Given this list of marker genes Car7, Drd2, Oxtr, Prkce, Cln3, Npy5r, Tac1, Pten, Cckbr, Slc38a1, Cntnap2, Hap1, Car2, Nalcn, Drd4, Plcl2, Kif5b, Adra1a, Kras (NCBI Gene Id 232521), Stxbp1, Nlgn2, Npas4 (neuronal PAS domain protein 4), Adora2a, Zdhhc3, Kcnk2, Zdhhc12, Nf1, Nlgn1, Phf24, Bdnf, Nisch (NCBI Gene Id 76966), Adora1, Cnr1, Baiap3, Nrxn1, Htr1b, Usp46, Tacr1, Cnr2, Slc6a1, Cntnap4, Dbi, Erbb4, Plcl1, Nps, Grik1 (NCBI Gene Id 28183), here is a description of the gene set: Any process that modulates the frequency, rate or extent of GABAergic synaptic transmission, the process of communication from a neuron to another neuron across a synapse using the neurotransmitter gamma-aminobutyric acid (GABA). Mouse Gene Set: GOBP_REGULATION_OF_SYNAPTIC_TRANSMISSION_GABAERGIC species: Mus musculus